The following is a description of a gene set: Phosphorylated BMAL1:CLOCK (ARNTL:CLOCK) activates expression of core clock genes studied in species Homo sapiens Human Gene Set: REACTOME_PHOSPHORYLATED_BMAL1_CLOCK_ARNTL_CLOCK_ACTIVATES_EXPRESSION_OF_CORE_CLOCK_GENES, and this is the list of marker genes: PER2, PER3, BHLHE40, TFEB, CREM, CRTC1, CLOCK, NR1D1, SIK1, BMAL1, NPAS2, CREB1, CIPC, CRY1, PER1, RORA, DBP, CRY2, RORC, KMT2A, CREBBP, RBM4